Given this list of marker genes ATP8A2, TACC2, RALYL, AKAP3, PLEKHB1, CYP11A1, MAGEA9, ABO, CLOCK, STXBP5L, THRA, ZNF157, PLXNA3, ZNF330 (zinc finger protein 330), ADCYAP1, SLC17A1 (NCBI Gene Id 6568), GLE1, SCAPER, COLGALT2, SLC16A5 (solute carrier family 16 member 5), SYT5, SLC17A7, PSG1, HTR1E, MYH2, TNFRSF25, KRT1, IL4, ABCA1 (NCBI Gene Id 8371), CRHR1, ELL2, PRELID3A, PAX7, SULT4A1, ENOX2, TSPYL1 (TSPY like 1), DRC3, TBXT, CAMK4 (NCBI Gene Id 814), RSC1A1, SLC13A2, TRIO (trio Rho guanine nucleotide exchange factor), ATP2B2, OR2B6, KRT86, RPH3A, SRPK3, NCKIPSD, ZNF202, CSRP3, SLC2A1, CCIN, PTPRS, PSD, here is a description of the gene set: Neighborhood of THRA species: Homo sapiens Human Gene Set: MORF_THRA Neighborhood of THRA thyroid hormone receptor, alpha (erythroblastic leukemia viral (v-erb-a) oncogene homolog, avian) in the MORF expression compendium